The following is a description of a gene set: Mouse Gene Set: GOCC_CILIARY_TIP studied in species Mus musculus Part of the cilium where the axoneme ends. The ciliary tip has been implicated in ciliary assembly and disassembly, as well as signal transduction., and this is the list of marker genes: Cilk1, Kif7, Ift88, Cyld, Gli2, Cluap1, Armc9, Spef1, Traf3ip1, Cdkl5, Rp1, Odad3, Ift52